Given this list of marker genes LGALS8, DDRGK1, CR1, XBP1, ITM2A, BCL6, IL2, IL10, NFKBIZ, NKX2-3, LGALS1, here is a description of the gene set: Human Gene Set: GOBP_PLASMA_CELL_DIFFERENTIATION species: Homo sapiens The process in which a B cell acquires the specialized features of a plasma cell. A plasma cell is a lymphocyte which develops from a B cell and produces high amounts of antibody.